Given this list of marker genes CSPG4, CHST14, DSEL, CSPG5, NCAN, VCAN, DCN, BCAN, BGN, CHST15, DSE, UST, here is a description of the gene set: Dermatan sulfate (DS) glycosaminoglycan chains consist of N-acetylgalactosamine (GalNAc) residues alternating in glycosidic linkages with glucuronic acid (GlcA) or iduronic acid (IdoA) residues. They are bound to the tetrasaccharide linker moiety of core proteins. As with CS, GalNAc residues can be sulfated in DS chains but also the uronic acid residues may be substituted with sulfate at the 2- and 4- positions. The steps below outline the synthesis of a simple DS chain (Silbert & Sugumaran 2002; reviewed in Mikami & Kitagawa, 2013). Reactome Pathway: DS-GAG biosynthesis part of: Chondroitin sulfate/dermatan sulfate metabolism studied in species Homo sapiens